The following is a description of a gene set: part of: Signaling by PTK6 species: Homo sapiens PTK6-mediated phosphorylation activates STAT3 transcription factor via STAP2 adapter protein. STAT3 transcriptional target SOCS3 is a negative regulator of PTK6 and inhibits PTK6-mediated phosphorylation of STAT3, thus creating a negative feedback loop. PTK6 may also activate STAT5-mediated transcription. Reactome Pathway: PTK6 Activates STAT3, and this is the list of marker genes: STAP2, SOCS3, STAT3, PTK6